The following is a description of a gene set: Genes down-regulated in CD8 T cells with STAT4: untreated versus interferon alpha. Human Gene Set: GSE40666_UNTREATED_VS_IFNA_STIM_STAT4_KO_EFFECTOR_CD8_TCELL_90MIN_DN Type 1 IFNs can conditionally activate all of the signal transducers and activators of transcription molecules (STATs), including STAT4. The best-characterized signaling pathways use STAT1, however, and type 1 IFN inhibition of cell proliferation is STAT1 dependent. We report that type 1 IFNs can basally stimulate STAT1- and STAT4- dependent effects in CD8 T cells, but that CD8 T cells responding to infections of mice with lymphocytic choriomenigitis virus have elevated STAT4 and lower STAT1 expression with significant consequences for modifying the effects of type 1 IFN exposure. The phenotype was associated with preferential type 1 IFN activation of STAT4 as compared to STAT1. Stimulation through the TCR induced elevated STAT4 expression, and STAT4 was required for peak expansion of antigen-specific CD8 T cells, low STAT1 levels, and resistance to type 1 IFN-mediated inhibition of proliferation. Thus, a mechanism is discovered for regulating the consequences of type 1 IFN exposure in CD8 T cells, with STAT4 acting as a key molecule in driving optimal antigen-specific responses and overcoming STAT1-dependent inhibition of proliferation. species: Homo sapiens from publication Gil MP, Ploquin MJ, Watford WT, Lee SH, Kim K, Wang X, Kanno Y, O'Shea JJ, Biron CA (PMID 22968462), and this is the list of marker genes: MEF2C, PTK2, ZNF100, IRF8, ABCA4, BRAF, TPST1, TCTN1, CD40, ZNF154, MAML2, CDC42BPB, PLSCR1, BMP2K, JARID2, SLC25A37, LYZL2, COA1, LNPEP, SATB1, KCNG1, PIWIL4, GRAP2, HPS4, SKAP1, ZNF492, PLEKHA1, VEZF1, SP140L, BSDC1, MAP3K8, ST3GAL1, PGGT1B, ATP6V0A1, L3MBTL3 (NCBI Gene Id 84456), INPP5A, ZNF557, UTRN, ZNF616, SLC12A2 (NCBI Gene Id 6558), CCR7 (NCBI Gene Id 1236), NR3C1, NUDT7, TRPC1, CHMP1B, KDM4C, BLOC1S2, SAV1, RSBN1, DISP1, EIF4G3, TARS3, GNB4, ZNF780B, USP13, NSD3, PCED1A, ARHGAP32, FANCB, PAIP2B, SLC16A7, VAV3, BLOC1S6, PDE8A, SIPA1L1, CDCA7L, TNRC6C, CRIP3, LAPTM5, SPEF2, ACVR1B (activin A receptor type 1B), GPR160, SBF2, STRADB, FLACC1, ZNF711, HELQ (helicase, POLQ like), ZNF135, BTG1, NRIP1, DCBLD2, BCL6, RALGAPA2, ZNF564, TBC1D8B, CNKSR2, SLC30A4, CEMIP2, HSF5, DENND11, TRAK2, GNB5, GCNT1, PUM1, TANGO6, PIK3IP1, TMEM263, BTLA, TAF3, TMLHE, PHF1, MYO9A, C12orf42, SHISAL2A, DPYD, BACH2 (NCBI Gene Id 653980), PPFIBP1, CD200, ZHX3, ATP10D, DENND2D, SLC38A11, RNF141, HYCC1, SMCR8, VPS13C, KANSL1L, FOXP1, PHC3 (polyhomeotic homolog 3), TSPAN3, DLEU2, BRMS1L, GBP4, FPGS (folylpolyglutamate synthase), P2RX1, MBTPS1, RUNX1, BEND5, SLC35D1, VEGFD (NCBI Gene Id 2277), CLCN4, STX7, TXNIP, PLPP5, TREML2, SLF1, CAAP1, FRYL, ABCB1, SESN1, MAPK13, ABCB4, NETO1, LYST, ZNF285, SARAF, KLF9, DYRK2, FAM177B, TAC3, ALDH2, NRF1, ZNF233, ZNF880, AGPAT5, ZNF514, ZNF318, USF3, CCNG2, SIN3A, NFYA, CHRAC1, POLR1HASP, SYT17, CRY1, UHRF2, MCTP2, ZFP28, ENAH, SH2D3A, UBE2E2, FAM169A, RASA1, C1orf162, PCMTD2, ZNF826P, PTPRK, APLP2, THRB, TPCN1 (NCBI Gene Id 56236), PECAM1, CA13, SAYSD1, ZNF649, MTHFR, NR3C2, MYO1B, TMPO, NBEA, TAF1, WWC3, P2RY14, FANCD2, FBXL4, CD207, JAZF1, TMF1, ZNF229, ZNF404